The following is a description of a gene set: species: Homo sapiens Supraventricular tachycardia Human Gene Set: HP_SUPRAVENTRICULAR_TACHYCARDIA Supraventricular tachycardia (SVT) is an abnormally increased heart rate (over 100 beats per minute at rest) with origin above the level of the ventricles., and this is the list of marker genes: DNMT3A, CALM2, SLMAP (sarcolemma associated protein), SEMA3A, HCN4, HCCS, KCNE5, NAA10, BMP2 (bone morphogenetic protein 2), ACTC1, KCTD1, SCN5A, SCN1B, MYH6, GATA4, SCN3B, ABCC9, TTN, TBX20, CACNA1C, FBXL4, TECRL, SCN2B, GATA6, NUP155, FLAD1, SLC19A2, KCNJ8, NDUFB11, RYR1, TRPM4, RYR2, SCNN1A, TNNI3K, SPRED1, CAP2, CALM3, CACNA1S, COX7B, KCNE3, CASQ2, MYL2, AKAP9, CITED2 (NCBI Gene Id 154106), ACTN2, MT-CYB, CACNB2, TRDN, NKX2-5, SCN10A, RANGRF, CALM1, GPD1L, LMNA (lamin A/C), CACNA2D1, PKP2, KCND3, TLL1